The following is a description of a gene set: species: Homo sapiens Human Gene Set: GOBP_POSITIVE_REGULATION_OF_MICROGLIAL_CELL_MIGRATION Any process that activates or increases the frequency, rate or extent of microglial cell migration., and this is the list of marker genes: TREM2, CSF1, CX3CL1 (C-X3-C motif chemokine ligand 1), P2RX4, CCL3, P2RY12